The following is a description of a gene set: studied in species Homo sapiens Genes up-regulated in monocytes (24h): muramyl dipeptide versus M. tuberculosis 19 kDa lipopeptide. human blood monocytes were isolated, activated and harvested at several timepoints In this study, we identified genes that were differentially expressed in human monocytes activated with eiter NOD2L and/or TLR2/1L. from publication Schenk M, Krutzik SR, Sieling PA, Lee DJ, Teles RM, Ochoa MT, Komisopoulou E, Sarno EN, Rea TH, Graeber TG, Kim S, Cheng G, Modlin RL (PMID 22447076) Human Gene Set: GSE34156_NOD2_LIGAND_VS_TLR1_TLR2_LIGAND_24H_TREATED_MONOCYTE_UP, and this is the list of marker genes: RBM27, ZNF462, BRD2, DLG5, NCR3, SCARNA17, DTNB, ILF3-DT, LTB, EMG1, ZNF574, CSNK1E, PRKCSH, TAL2 (TAL bHLH transcription factor 2), TMEM151A, SLC13A3, KIT, WFDC8, PODN, PIN1, LINC01550, RXFP1, FAP, NDRG2, LINC01128, SLC7A1 (solute carrier family 7 member 1), AGBL1, MAF, ANK1, KIAA0825, CEP112, WWC2-AS2, PPIB, KLRB1, TDH-AS1, KCNN3, TUSC2, UNC13D, G3BP1, JPH3, SLC15A1, JADE1, HMCN1, ANKRD36, SFMBT1, SLAIN2, CD70, OR5V1, C8orf33, LARP1B, DEFT1P, ERCC6L, SLAMF1, KMT2D, EIF4B, GNAT3, GFPT1, SENP3, KLRG1, FKBP11, SFTPC, MLANA, PPP4R3C, NUP153, B4GALNT3, LINC02843, IL21R-AS1, RAB4A, MXD4, SPMIP10, FREM1, WNT11, HOXB5, GPRIN3, CYP4F8, FOXRED2, ZNF596, PTPRZ1, BLK, UMODL1-AS1, BEST4, ROPN1L (NCBI Gene Id 83853), SDCBP2-AS1, JUN, MTMR9LP, N4BP3, PPDPF, RRAS2, LHFPL3-AS1, SCART1, HUNK, SLC4A10, H4C11, NAA30, CDH5, CEACAM6, ODF2L, FAM43A, CDC14A, CA5B, CYBA, ITGB7, TAS2R8, NCS1, DLAT, TRPC4, CIAO2B, PLEC, ADCY9 (NCBI Gene Id 115), CFAP68, CCSAP, SPOCK2, CCR6, TEX35, MAPK8IP2, ABHD15, LINC02481, HOXB-AS3, FMNL1, PRELID3B, DPPA2, EIF4G1, ADAMTS20, AP1M2 (NCBI Gene Id 10053), RBMS1, DDX54, EPB41L4B, TMEM184B, LINC01541, ELL, CACNB3, PTPN11, LIMK1, RNF6, KLC2, ARID1A, RBM48, CYP17A1, MPZL3, UNC119, NFKB2, ATP6V0A2, LYAR, DPP4, ITPR3, PLPPR5, TBKBP1, GADL1, NUDT4, AQP6, DCAF4L1, IQCC, SI, RORC, LINC01845, RAB8B (RAB8B, member RAS oncogene family), TMEM182, NOXRED1, GPRC6A, ATP6V0A4, DNAJC5G, CA4, KCNH8, FGFRL1, HS6ST3, KIAA2012-AS1, SNORA74A, WDTC1, PPP2R5A, TAS2R10, FEN1, LINC01020, ALMS1P1, BTN2A3P, SURF4, INO80E, BCCIP, MAZ, SKIL, BVES, SSC4D, PSMG3, CNGB1, PPM1A, FIGN, C9, FERMT2, GRIK2, SCARNA2, LPCAT3